Given this list of marker genes LTA4H, GPX4, ALOX5, here is a description of the gene set: species: Homo sapiens Reactome Pathway: Biosynthesis of aspirin-triggered D-series resolvins part of: Biosynthesis of DHA-derived SPMs The D-series resolvins (RvD1-6) are biosynthesised from the precursor ω-3 fatty acid docosahexaenoic acid (DHA), either via the lipoxygenase pathway (17(S)-RvDs) or via aspirin-triggered cylcooxygenase catalysis (described here) forming the epimeric 17(R)-RvD1-6 resolvins.